Given this list of marker genes DHH, PSMB6, ARRB2, PSMD7, DZIP1, IQCE, SMURF1, RBX1, GLI2, PSMD12, EFCAB7, SEM1, PSMC3, PSMA7, SUFU, PSMB5, ULK3, EVC, GLI3, PSMB7, PSMD6, PSMA5, PSMD2, PSMB4, GRK2, KIF7, EVC2, PSMD8, IHH, PSMC6, PSMA1, CUL3, SPOPL, UBC, CSNK1A1, PSMD3, PSMA4, ARRB1 (arrestin beta 1), PSMB1, PSMA3, GAS1, PSMB3, PSMC4, PSMD1, PTCH2, ITCH, UBB, PSMB2, PSMD11, ADRM1, HHIP, PSMA2, PSMD14, PSMC2, CDC73, PSMC1, GPR161, SMO, UBA52, KIF3A, SMURF2, PTCH1, CDON (NCBI Gene Id 50937), GAS8, BOC, SHH, PSMA6, GLI1, PSMD13, PSMC5, SPOP, NUMB, RPS27A, here is a description of the gene set: studied in species Homo sapiens Human Gene Set: REACTOME_HEDGEHOG_ON_STATE Hedgehog 'on' state